Given this list of marker genes Gm28729, Coro1a, Vil1, Carmil3, Gsn, Arf1, Wasf1 (WASP family, member 1), Ap1ar, Fmn1, Carmil1, Rnh1, Cyfip1, Whamm, Arfip2, Trim27, Carmil2, Wasf2, Washc1, Magel2, Washc5, Fchsd2, Washc4, Wasf3, Wmp, Washc3, Arpin, Hip1r, Nckap1, Scin, Washc2, Gmfg, Dnai3, Coro1b, Gmfb, Abi2, Brk1, Arfip1, Pick1, Ctnna2, here is a description of the gene set: Any process that modulates the frequency, rate or extent of actin nucleation, the initial step in the formation of an actin filament in which actin monomers combine to form a new filament. species: Mus musculus Mouse Gene Set: GOBP_REGULATION_OF_ACTIN_NUCLEATION